Given this list of marker genes MT4, MT1X, MT3, MT1E, MT1F, MT1A, ATP7A, MT1DP, PARK7, MT1M, MUC2, MT1H, MT2A, MT1G, MT1HL1, MT1B (NCBI Gene Id 81836), here is a description of the gene set: Any process that reduces or removes the toxicity of copper ion. These include transport of copper away from sensitive areas and to compartments or complexes whose purpose is sequestration of copper ion. species: Homo sapiens Human Gene Set: GOBP_DETOXIFICATION_OF_COPPER_ION